Given this list of marker genes NTRK1, NGF, here is a description of the gene set: Neurotrophin functions are mediated by binding of the secreted neurotrophin homodimers to their common neurotrophin receptor p75NTR, and to their cognate tropomyosin related kinase (TRK) receptor. NGF binds to TRKA, BDNF and NT4 bind to TRKB, NT3 binds to TRKC. A tri-molecular signalling complex (NGF-p75NTR-TRKA) might also be possible. part of: Activation of TRKA receptors studied in species Homo sapiens Reactome Pathway: TRKA activation by NGF